Given this list of marker genes Cpsf1, Wdr33, Cpsf3, Snrpg, Zfp473, Lsm11, Clp1, Fip1l1 (factor interacting with PAPOLA and CPSF1, NCBI Gene Id 66899), Snrpf, Papola, Slbp, here is a description of the gene set: Reactome Pathway: Processing of Capped Intronless Pre-mRNA This event has been computationally inferred from an event that has been demonstrated in another species.<p>The inference is based on the homology mapping from PANTHER. Briefly, reactions for which all involved PhysicalEntities (in input, output and catalyst) have a mapped orthologue/paralogue (for complexes at least 75% of components must have a mapping) are inferred to the other species. species: Mus musculus part of: Metabolism of RNA electronically inferred by orthology from the curated human pathway